The following is a description of a gene set: Reactome Pathway: Mitochondrial unfolded protein response (UPRmt) part of: Cellular responses to stress studied in species Homo sapiens Misfolded proteins in mitochondria activate the mitochondrial unfolded protein response (mtUPR), a program of gene expression that increases capacities for protein folding and protein degradation within the mitochondria. Four interrelated pathways that regulate the mtUPR have been delineated: activation of Heat Shock Factor 1 (HSF1) by dissociation from HSPA1A,B (HSP70), enhanced translocation of ATF5 to the nucleus, activation of the estrogen receptor alpha (ESR1) by phosphorylation, and activation of FOXO3 by deacetylation.<br> The mtUPR appears to be initiated by the accumulation of reactive oxygen species (ROS) and mitochondrial precursor proteins in the cytosol. The ROS oxidize cysteine residues on DNAJA1, causing DNAJA1 to displace HSF1 from the chaperone HSPA1A,B (HSP70). HSF1 then transits to the nucleus, trimerizes, and activates expression of genes encoding chaperones.<br>The transcription factor ATF5, which is normally imported into mitochondria, instead accumulates in the cytosol and transits to the nucleus, where it acts with HSF1 to increase expression of chaperone genes. ATF5 may act downstream of HSF1, as ATF5 is not required to initiate the mtUPR.<br>ROS also activate the protein kinase AKT1 (PKB), which phosphorylates the estrogen receptor ESR1. Phosphorylated ESR1 transits to the nucleus and, independently of estrogen, activates the expression of HTRA2 (OMI), NRF1, and other genes involved in mitochondrial homeostasis as part of the mitochondrial unfolded response.<br>Through an uncharacterized mechanism, ROS cause increased expression of the deacetylase SIRT3, which directly or indirectly causes the deacetylation of the transcription factor FOXO3. Deacetylated FOXO3 in the nucleus increases expression of the antioxidant enzymes mitochondrial superoxide dismutase (SOD2, MnSOD) and peroxisomal catalase (CAT) in the mitochondrial unfolded response. <br>Though ATF4 and CHOP are also key regulators of the mtUPR, the mechanisms that activate them in response to unfolded protein are not well characterized and may involve the phosphorylation of the EIF2S1 subunit of the translation factor eIF2alpha; however, none of the four known EIF2S1 kinases (GCN2, HRI, PERK, and PKR) are required for activation of CHOP., and this is the list of marker genes: LONP1, DEFA5, SOD2, HSPE1 (NCBI Gene Id 82869), CAT, HTRA2, HSPA9, HSPA1A, HSPA1B, DNAJA1, ATF5, HSPD1, FOXO3, SIRT3, HSF1, NRF1, ESR1, AKT1